Given this list of marker genes ERCC4, GTF2F1, EDF1, GTF2A1, RUVBL1, ESR1, RUVBL2, HNRNPU, TP53, FBL, NOP58, TAF1, AR, CTDP1, TAF7, TBP, AHR, FOXF2 (forkhead box F2), GTF2E2, ZNHIT6, DRAP1, GTF2A2, TCF4, ERCC1, here is a description of the gene set: studied in species Homo sapiens Human Gene Set: GOMF_RNA_POLYMERASE_II_GENERAL_TRANSCRIPTION_INITIATION_FACTOR_BINDING Binding to a basal RNA polymerase II transcription factor, any of the factors involved in formation of the preinitiation complex (PIC) by RNA polymerase II and defined as a basal or general transcription factor.